Given this list of marker genes Prl3d3, Xbp1, Prl3a1, Prl2c3 (prolactin family 2, subfamily c, member 3), Prl2c5, Prl8a6, Prl8a9, Prl7c1, Prl4a1, Prl2b1, Prl2a1, Prl3d2, Prl, Prl7a2, Prl2c2, Prl6a1, Prl3b1, Prl8a1, Prl7b1, Prl7d1, Prl8a2, Prl8a8, Prl2c1, Prl3d1, Prl5a1, Prl3c1, Oas2, Prl7a1, here is a description of the gene set: species: Mus musculus Mouse Gene Set: GOBP_REGULATION_OF_LACTATION Any process that modulates the frequency, rate or extent of lactation.